Given this list of marker genes Syt1, Ptprn2, Cplx3, Atp6v1g2, Atp6v0a1 (ATPase, H+ transporting, lysosomal V0 subunit A1), Slc18b1, Slc2a3, Lrrk2, Mctp1, Rab4b, Wfs1, Anxa5, Rab14, Rab27b (RAB27B, member RAS oncogene family), Slc17a7, Atp6v0d1, Slc30a3, Sypl2, Sgta, Rab5c, Pi4k2a, Dgki, Gria2, Lamp1, Phf24, Unc13b, Slc9b2, Snca, Arpc2, Atp6v1e1, Tprg1l, Atp6v1g1, Rab5a, Sypl1, Rab3c, Apc, Rab5b, Slc17a6, Slc6a2, Mctp2, Atp6ap1, Atp6v1f, Rac1, Stx12, Syt8, Calm2, Gabra2, Tafa4, Amph, Dlg1, Prrt2, Mff, Rab3b, Atp6v1g3, Sh3gl2, Bin1 (bridging integrator 1), Anp32e, Cbarp, Rab10, Syngr1, Atp6v0e2 (ATPase, H+ transporting, lysosomal V0 subunit E2), Atp6v1c1 (ATPase, H+ transporting, lysosomal V1 subunit C1), Atp6v1b1, Rab7, Abcc8, Syt2, Slc6a9, Slc18a2, Syt9, Slc10a4, Calm1, Doc2b, Atp6v0a4, Doc2a, Prkn, Prrt1 (proline-rich transmembrane protein 1), Calm3, Slc18a1, Slc17a8, Atr, Btbd8, Scamp5, Gad2, Syt6, Rab2a, Rab3a, Vamp1, Slc18a3, Atp6ap2, Atp6v1h, Atp6v1b2, Unc13c, Grin1, Slc35d3, Sv2a, Septin8, Atp8a1, Syt12, Rab26, Ptprs, Clta, Syp, Slc35g2, Snapin, Slc22a2, Slc5a7, Stx7, Stx1a, Syn1, Cltc, Syngr4, Oprd1, Znrf1, Atp2b1, Rab35, Dmd, Borcs5, Clcn3, Sema4c, Bcl2l1, Slc4a8, Kif1b, Svop, Gpr151, Rph3a, Syn2, Tmem163, Syt7, Syngr2, Dtnbp1, Scamp1, Dmxl2, Vamp2, Gria1, Dnm1l, Syt11, Ppt1, Atp6v0c, Vamp3, Lamp5, Atm, Syn3, Cltb, Trpm7, Mal2 (NCBI Gene Id 223579), Slc17a5, Syt5, Atp6v1a, Snap29, Unc13a, Slc35f1, Otof, Oprk1, Sv2c, Stx6, Slc6a17, Drd2, Rab4a, Phaf1, Synpr, Syt13, Ica1, Syndig1, Rab11b, Syngr3, Dlg2, Dnajc5, Atp6v1d, Stx16, Slc32a1, Slc6a7, Sv2b, here is a description of the gene set: species: Mus musculus The lipid bilayer surrounding a synaptic vesicle. Mouse Gene Set: GOCC_SYNAPTIC_VESICLE_MEMBRANE